The following is a description of a gene set: The chemical reactions and pathways involving neutral lipids, lipids only soluble in solvents of very low polarity. Mouse Gene Set: GOBP_NEUTRAL_LIPID_METABOLIC_PROCESS studied in species Mus musculus, and this is the list of marker genes: Dbi, Ang5, Slc27a5, Plpp1, Cpt1a, Aadac, Pcsk9, Lipa, Nkx2-3, Mfsd2a, Pnpla2, Lipg, Insig1 (NCBI Gene Id 69039), Abhd16a, Abca17, Pnliprp1, Avil, Pank2, Pnlip, Kat5, Snca, Dgat1, Apobec1, Scd1, Fitm2, Plce1, Ccnc, Pnpla3, Lmf1, Mgll, Sorl1, Slc22a4, Ces1g, Dgke, Pnliprp2, Acsl6, Apob, G6pc1, Cdk8, Gpihbp1, Abhd16b, Pla2g4a, Gpam, Plb1, Apoa5, Gnb3, Apobr, Lpin1, Gk2, Atg14, Abhd12b, Dgkz, Lipe, Acsl5, Tbl1xr1, Dgkg, Apoc3, Cnep1r1, Cyp2e1, Gpld1, Mboat7, Gpat2, Pla2g15, Lpin3, Pik3cg, Agmo, Lipc, Daglb, Dgka, Ces1d, Tmx1, Lpin2, Cps1, Dgkk, Ang6, Ldlr, Gpat4, Tmem68, Pnpla5, Sirt1, Pnpla1, Acsl1, Thrb, Angptl3, Sik1, Dgat2, Fgf21, Lpgat1, Ang2, Dgat2l6, Mogat1, Pgs1, Apoa2, Esr1, Ctdnep1, Mogat2, Thrsp, Apoc2, Plaat3, Abhd12, Plin5, Dgkq, Dgkb, Dgki, Apoc1, Cat, Scarb1, Apoa4, Dgkh, Faah, Gpr82, Nr1h3, Apoh, Nr1h2, Gk5, Gk, Slc27a1, Abhd5, Lypla2, Pck1, Gykl1, Blvra, Abhd2, Agpat5, Rgn, Apoc2l, Ptpn11, Ddhd2, Apof, Cav1, Il6st, Mttp (microsomal triglyceride transfer protein), Insig2, Cav3, Gpx1, Abhd6, Dgkd, Awat2, Dagla, Ang4, Apoe (apolipoprotein E), Gpat3, Rbp2, Agpat2, Mir423, Tnxb, Slc37a4 (NCBI Gene Id 14385), Srebf1, Nr1h4, Serpina12, Pck2, Tcf7l2, Ang, Sel1l, Cidec, Acsl4, C3, Cideb, Lpl